The following is a description of a gene set: studied in species Mus musculus Mouse Gene Set: GOBP_POSITIVE_REGULATION_OF_MONOCYTE_CHEMOTAXIS Any process that increases the frequency, rate, or extent of monocyte chemotaxis., and this is the list of marker genes: Cxcl10, Ccl1, Cx3cr1, Fpr2, Ccr1l1, Fpr-rs4, Lgmn, Ccr1, Creb3, Cxcl17, Mospd2, Fpr-rs3, Hmgb1, Fpr-rs6, Defb25, Ano6, Fpr-rs7 (formyl peptide receptor, related sequence 7), S100a14, Aif1, Serpine1, Tnfsf18, Cxcl12, Pla2g7, Ccl2, App, Ccr2, Ccl5